The following is a description of a gene set: The attachment of one cell to another cell via adhesion molecules that require the presence of calcium for the interaction. Human Gene Set: GOBP_CALCIUM_DEPENDENT_CELL_CELL_ADHESION_VIA_PLASMA_MEMBRANE_CELL_ADHESION_MOLECULES species: Homo sapiens, and this is the list of marker genes: CDH10, CDH20, PCDHB3, CDH3, CDH6, CDH12, PCDHB10, CDH2, PCDHB6, PCDHB16, DSG1, CDH9, PCDHB11, CDH1, KIFAP3, CDH8, CDH17 (NCBI Gene Id 1015), ATP2C1, PCDHB2, CDH5, SELP, NLGN1, PCDHB13, PCDHGB4, CDH13, PCDHB9, PCDHB5, PCDHB14, PCDHGC3, CDH4, NRXN1, PCDH12, SELL, CDH16, CDH7, AJUBA, FXYD5, CDH23, CDH26, DCHS1 (NCBI Gene Id 8642), CDH15, CDH24, PCDHB4, CDH22, CDHR3, CDH18, CDH11, CDH19 (NCBI Gene Id 28513, cadherin 19)